Given this list of marker genes HDAC4, PPP1CB, CDK5RAP2, ZEB2, ALX4, CDC42, CAMK2B, DPH1, TBC1D24, TAF4, EIF2S3, NONO, DLX3, B3GLCT, SSR4, AIP, KMT2D, AXIN2, KATNB1, RAD21, MECP2, BCAS3, MSX1, SMC1A, ADNP, CLP1, AIMP2, BRD4, MED12, TP63, CDH3, KIAA0753, TWIST2, MED13L, LMBRD2, GJA5, PIGL, GLB1, FGF10, WDR35, RDH11, ZSWIM6, CDK19, WNT10B, BAP1, LRP6, ZNF526, TGFA, IFT140, DPH2, CCDC47, CERT1, SETD1A, PIGS, LARP7, ARSK, MAPK1, PCGF2, WDR26, AFF3, NIPBL, NARS1, PAX9, CDC42BPB, ERCC6, RPS6KA3, KDM1A, PRKD1, SMARCA2, RHOBTB2, LTBP3, EDA, TAF6, CHD3, PRR12, H4C5, CHST3, MED27, MAN2B1, SATB1, FGF3, ERCC8, ACVR1, KANSL1, NAA20, CEP295, SHANK3, TBL1XR1, PTPRF, PACS2, SUMO1, IFT122, GUSB, ATP6V1B2, GALNS, ACP4, CNTNAP2, TBCD, RLIM, TBX4, IRF6, DRG1 (developmentally regulated GTP binding protein 1), IFT43, NDST1, EDARADD, RNF113A, ERCC1, OCA2, SMC3, DYRK1A, HDAC8, AHDC1, GJA8, NECTIN4, IFT52, MBD5, KDM6A, UBE3A, IDS, TCF4, FGFR1, WNT10A, ERCC4, HK1, TTI1, PIGA (NCBI Gene Id 5277), GPR101, SNRPN, TANC2, here is a description of the gene set: species: Homo sapiens Human Gene Set: HP_WIDELY_SPACED_TEETH Widely spaced teeth Increased spaces (diastemata) between most of the teeth in the same dental arch.